Given this list of marker genes IL12A, GBP4, FCRL1, STK17B, IRF9, YAE1, LGALS9B, BEND3, PPM1K (NCBI Gene Id 152926), RSAD2, DENND3, FMR1, NCF1, SMAGP (NCBI Gene Id 57228), TOR1AIP2, SYPL1, IRGM, AQR, CMPK2 (cytidine/uridine monophosphate kinase 2), DHX58, BCL2, IFI35, RIGI, FCER2, IFIT2, SMARCE1, AZIN1, TMCC3, PHIP, SKIL, ISG20, CTSC, ZFP62, GPR18, RICTOR, USP22, PIKFYVE, FAM89A, RAB34, CDC27, BABAM2, IRF7, PXN, MCMBP, TMED8, ICOSLG, BCL3, RBM26, KCTD14, CCRL2, C6orf62, NAMPT, ARID3B, PCGF3, GIMAP8, SLAMF1, IDH3A, HORMAD1, HELZ2, WIZ, ZNF281, ZNFX1, TRAFD1, MYO5A, MYO19, HEATR6, PSMB9, LNPEP, BCAR3, PPFIBP2, TP53, CLCF1, VARS2, EIF4E, IRF2BP2, ACP6, ILRUN, UAP1, RNF114, PCMTD1, TAP1, TFG, ARHGAP22, ZNF687 (zinc finger protein 687), GPER1, IFI27 (interferon alpha inducible protein 27), PARP14, DTX3L, RAB8A, CYBB, RTP4, GIMAP4, CMTR1, RNF213, SPC24, XAF1, PIAS1 (NCBI Gene Id 8695), FAM167B, BICDL1, ZMYND10, NIBAN1, CPNE3, RRAS2, MFAP1, MS4A6A, ANXA1, TLR1, TAF7, GRAMD2B, NFKBIA, SLC4A7, TMEM168, SELL, KDR (NCBI Gene Id 3791), KIF5B, HACL1, GADD45B, ZC3H12A, TMEM184B, CDK1, PECAM1, PIM2, STAT1, ADCY6, IFNLR1, NDEL1, SOCS3, IZUMO4 (NCBI Gene Id 113177), CA13, GOT1, LGALS3BP, BEND5, MRGBP, GBP6, PELI1, STRIP2, CCL5, PIK3AP1, ANKRD42, ID1, BBX (NCBI Gene Id 56987), SLFN13, SLC43A3, KSR1, UBTD2, FSCN1, EZH2, FUT8, HIVEP1, SWAP70, TLR7, JUN, OPTN, CXCL10, ITPKB, PMEPA1, SOCS5, RBM33, FAM174A, BATF, BST2, SLFN12, UGCG, PARP9, DDX11, CBLB, SRSF11, USP15, SERINC1, IL18R1, PRKAA2, HECA, PML, PARP12, HNF1B, HACD3, B3GALT6, ZDHHC13, GOPC, CD47, IL6, SENP5, BDH1, NFKB1, ATP10D, FAM107B, AKT3 (AKT serine/threonine kinase 3), EVX1 (NCBI Gene Id 2128), FGF3, CD19, TNFSF9, STAG2, NUP160 (nucleoporin 160), EBI3, MYEF2, GPSM2, ZRANB1, SNAP23, PRMT1, here is a description of the gene set: Human Gene Set: GSE43863_TFH_VS_LY6C_LOW_CXCR5NEG_EFFECTOR_CD4_TCELL_UP Genes up-regulated in CD4 SMARTA effector T cells during acute infection of LCMV: follicular helper (Tfh) versus Ly6c low CXCR5-. studied in species Homo sapiens CD4 T follicular helper (Tfh) cells provide the required signals to B cells for germinal center reactions that are necessary for longlived antibody responses. However, it remains unclear whether there are CD4+ memory T cells committed to the Tfh lineage after antigen clearance. Using adoptive transfer of antigen-specific memory CD4+ subpopulations (based on CXCR5 and Ly6c expression)in the LCMV infection model, we found that there are distinct memory CD4+ T cell populations with commitment to the Tfh and Th1 lineages. Our conclusions are based on gene expression profiles, epigenetic studies and phenotypic and functional analysis. The gene expression profiles of virus-specific CD4 T cell subets at effector and memory stages is presented here. from publication Hale JS, Youngblood B, Latner DR, Mohammed AU, Ye L, Akondy RS, Wu T, Iyer SS, Ahmed R (PMID 23583644)